Given this list of marker genes COL5A1, COL5A2, CCN4, SLC25A43, WIPF1, THBS4, COL3A1, LYZ, IFI44, THBS2, SFRP4, PRRX1, ASAP1, LOX, GMFB, FBN1, ECT2, INVS, MXRA5 (NCBI Gene Id 91006), ZNF823, CTHRC1, TMEM119, ADAM12, LAMB1, COL12A1, SRPX, LCP2, NACA, AEBP1, MMP2, VCAN, STK39, BTN3A3, CDK8, COL1A2 (NCBI Gene Id 1278), CAP2, LIG3, PABPC1L, EPPK1, COL11A1, UGCG, POSTN, TACC3, FNDC1, MIR1245A, COL8A1, RAB26, COL10A1, COL1A1, MMP11, TAGAP, PDE8A (phosphodiesterase 8A), CXCR4, COL4A1, TYMS, SPP1, ZNF805, TMEM65, ASPN, FN1, BGN, SULF2, GNA13, SAR1B, COL4A2, RFTN1, C5AR1, RGS1, COMP, NEAT1, SFRP2, RABEP2, COL6A3, LRRC15, here is a description of the gene set: species: Homo sapiens Human Gene Set: TURASHVILI_BREAST_LOBULAR_CARCINOMA_VS_LOBULAR_NORMAL_DN Genes down-regulated in lobular carcinoma vs normal lobular breast cells. from publication Turashvili G, Bouchal J, Baumforth K, Wei W, Dziechciarkova M, Ehrmann J, Klein J, Fridman E, Skarda J, Srovnal J, Hajduch M, Murray P, Kolar Z (PMID 17389037) BACKGROUND: Invasive ductal and lobular carcinomas (IDC and ILC) are the most common histological types of breast cancer. Clinical follow-up data and metastatic patterns suggest that the development and progression of these tumors are different. The aim of our study was to identify gene expression profiles of IDC and ILC in relation to normal breast epithelial cells. METHODS: We examined 30 samples (normal ductal and lobular cells from 10 patients, IDC cells from 5 patients, ILC cells from 5 patients) microdissected from cryosections of ten mastectomy specimens from postmenopausal patients. Fifty nanograms of total RNA were amplified and labeled by PCR and in vitro transcription. Samples were analysed upon Affymetrix U133 Plus 2.0 Arrays. The expression of seven differentially expressed genes (CDH1, EMP1, DDR1, DVL1, KRT5, KRT6, KRT17) was verified by immunohistochemistry on tissue microarrays. Expression of ASPN mRNA was validated by in situ hybridization on frozen sections, and CTHRC1, ASPN and COL3A1 were tested by PCR. RESULTS: Using GCOS pairwise comparison algorithm and rank products we have identified 84 named genes common to ILC versus normal cell types, 74 named genes common to IDC versus normal cell types, 78 named genes differentially expressed between normal ductal and lobular cells, and 28 named genes between IDC and ILC. Genes distinguishing between IDC and ILC are involved in epithelial-mesenchymal transition, TGF-beta and Wnt signaling. These changes were present in both tumor types but appeared to be more prominent in ILC. Immunohistochemistry for several novel markers (EMP1, DVL1, DDR1) distinguished large sets of IDC from ILC. CONCLUSION: IDC and ILC can be differentiated both at the gene and protein levels. In this study we report two candidate genes, asporin (ASPN) and collagen triple helix repeat containing 1 (CTHRC1) which might be significant in breast carcinogenesis. Besides E-cadherin, the proteins validated on tissue microarrays (EMP1, DVL1, DDR1) may represent novel immunohistochemical markers helpful in distinguishing between IDC and ILC. Further studies with larger sets of patients are needed to verify the gene expression profiles of various histological types of breast cancer in order to determine molecular subclassifications, prognosis and the optimum treatment strategies.